Given this list of marker genes SLC25A13, H6PD, HTR3A, SRGAP3, PHLPP2, CORO6, CHST13, EAF1, PTGDS, ANXA1 (NCBI Gene Id 301), UAP1, DDX54, PRSS58, CLIP4, LARGE1, CEP112, CMA1, AMOT, MAPKAP1, PABPC1, REG3A, POLM, FAM163A, POGLUT3, COQ2 (NCBI Gene Id 27235), DAPK3, SCARNA17, SFRP2, ADAM29, GNG2, GUSB, CLEC9A, RAB27A, FAM222B, SNRPB2, HGS (hepatocyte growth factor-regulated tyrosine kinase substrate), P2RX7, HGD, TMPRSS11A, LDLR, PTGIR, UBE2L3, MED16, GHR, TTC23L, SEMA4D, IFNA13, MLST8, LY6E, CFAP58, FBXL4, GALNT10, CPEB2, LUM, E2F3, LPCAT3 (lysophosphatidylcholine acyltransferase 3), MRAP, RGS18, RNF135, STX2, ZYG11A, NUP42, GPR173, LAP3, MSR1, TRPC6, LRRC19, SCLY, CLCA4, MRPS25, WAS, NKG7, TOX, BICRA, GOLM2, MBD2, LRRC26, SF3A1, NAT1, FBF1, CTSW, VEGFC, LYPLAL1, CYP11A1, HDAC9, NUFIP1, IL12RB1, PSMA2, SC5D, TGFBRAP1, MTMR14, IL1RL1, MTCH1, MIR154, CYFIP1, ETV1, TMEM67, GALP, ARAP1, TM4SF5 (NCBI Gene Id 9032), MT1A (metallothionein 1A), GPR83, ABI2, LAPTM5, GPATCH3, PPIA, C9, SLC30A8, RORA, PTGR1, DHPS, MUC3A, MIR409, TMEM150A, CTNS, SERINC3, PI4KA, LIPE, GPR155 (G protein-coupled receptor 155), CNTNAP4, FHIP1A, PADI4, ITPR3, TRIM7, SRD5A3, NIPSNAP2, FAM118B, ATP6V0A2, PRKAR2A, RDH5, PHC3, MCOLN1, SEMA3E, TRPC3, MAPK8IP3, CLEC1A, ABCD4, ZIC5, here is a description of the gene set: Genes down-regulated in skin from BALB/c mice after injection of: control versus Trypanosoma cruzi (strain G). To investigate the early host response triggered by three different strains of Trypanosoma cruzi at a local infection site, changes in host gene expression were monitored in a murine intradermal infection model using Affymetrix oligonucleotide arrays. Robust induction of IFN-stimulated genes (ISGs) was observed in excised skin 24 hours post-infection where the level of ISG induction was parasite strain-dependent with the least virulent strain triggering a muted IFN response. Infection of mice immunodepleted of IFNγ-producing cells or infection of IFNγ-deficient mice had minimal impact on the IFN response generated in T. cruzi infected mice. In contrast, infection of mice lacking the type I IFN receptor demonstrated that type I IFNs are largely responsible for the IFN response generated at the site of infection. These data highlight type I IFNs as important components of the innate immune response to T. cruzi the site of inoculation and their role in shaping the early transcriptional response to this pathogen. We used microarrays to detail the local host transcriptional response to intradermal T. cruzi infection in WT mice and mice depleted of NK cells, or deficient in IFN-gamma or type I IFN responses. Additionally we compared the local host-transcriptional response generated to infection with 3 different strains of Trypanosoma cruzi (Y, Brazil, and G). from publication Chessler AD, Unnikrishnan M, Bei AK, Daily JP, Burleigh BA (PMID 19201883) Human Gene Set: GSE13522_CTRL_VS_T_CRUZI_G_STRAIN_INF_SKIN_DN species: Homo sapiens